The following is a description of a gene set: species: Mus musculus Mouse Gene Set: GOBP_SENSORY_PERCEPTION_OF_SOUR_TASTE The series of events required to receive a sour taste stimulus, convert it to a molecular signal, and recognize and characterize the signal. This is a neurological process., and this is the list of marker genes: Pkd1l3, Scnn1a, Scnn1g, Pkd2l1, Scnn1b, Asic1, Asic2, Asic3